Given this list of marker genes STK17B, SAMSN1, PPP2R5C, GPRIN3, STK4, RPS29, FNBP1, RGCC, AUTS2, PDE4D, CXCR4, BCL11B, JUNB, SMCHD1, CD69, AKNA, BTG1, XCL1, TSC22D3 (TSC22 domain family member 3), LCP1, ATP1B3, CD52 (CD52 molecule), SMAP2, PARP8, GPR171 (NCBI Gene Id 29909), CELF2, EVI2A, NFKB1, AREG, RASSF5, IL2RG (interleukin 2 receptor subunit gamma), SPOCK2 (NCBI Gene Id 9806), CXCL13, MAF, LEPROTL1, ZC3HAV1, SRGN, PIK3R1, PRDM1, FAM177A1, KLRB1, CYTIP, SLA, DUSP4, TNFAIP3, PDE7A, WIPF1, CDC42SE2, SYTL3, SARAF, SH2D2A (SH2 domain containing 2A), GATA3, RGS1, RBPJ, CD53, ITK, USP36, SATB1, FYN, CD40LG, EML4, RPS27A, PTGER4, RPL36A, EMB, CREM, RUNX3, TENT5C, TENT4B, PTPRC, TRBC2, RPS27, CRYBG1, PPP1R2, MYBL1, NR3C1, ARHGDIB, NIBAN1, TCF7, STK17A, TRAC, LEF1, PPP1CB, ZNF331, CD44, KIT, SLC38A1, PIM2, IL7R, ZFP36L2, CXCR6, PDCD4, RNF125, CNOT6L, RCAN3, PBXIP1, TXNIP, ETS1, ANXA1, here is a description of the gene set: studied in species Homo sapiens from publication Aizarani N, Saviano A, Sagar, Mailly L, Durand S, Herman JS, Pessaux P, Baumert TF, Grün D (PMID 31292543) Human Gene Set: AIZARANI_LIVER_C28_NK_NKT_CELLS_6